Given this list of marker genes PARP1 (NCBI Gene Id 142), ATM, RUVBL1, SETMAR, TWIST1, NBN, ABL1, RADX, ACTR2, ACTL6B, DPF2 (double PHD fingers 2), RMI2, PARPBP, PML, MAD2L2, SMARCA2, KDM4D, BRD7, CYREN, RAD51AP1, PRMT1, SMARCC2, TEX15, NSD2, ZCWPW1, ARID1A, WAS, PPP4R3C (protein phosphatase 4 regulatory subunit 3C), FBH1, POLQ, PPP4R2, WDR48, UBE2N, MEAF6, RIF1, SHLD1, MGMT, SHLD2, ARID2, ATR, TP53BP1, PBRM1, SLF2, PPP4R3A, RAD50, SKP2, CREBBP, OTUB1, MORF4L1, SHLD3, SMARCD1, SETD2, MIR221, KLHL15, FOXM1, SMARCB1, SPIRE2, YEATS4, BCL7B, MRE11, UBQLN4, RTEL1, DMAP1, KMT5C, RNF169, FH, UBE2V2, CSNK2A1, HSF1, TOP2B, PELI1, OGG1, PIAS4, PPP4C, DDX11, MRGBP, FANCB, ZNF365, PHF10, PNKP, DEK, KMT5A, USP51, EPC1, FIGNL1, WRAP53, HELQ, EP400, SLF1, SPIRE1, PLK1, TFIP11, ATRIP, TERF2IP, HDGFL2, MAGEF1, ARID1B, POT1, ACTL6A, SMARCD3, HELB, KMT5B, SMARCA4, TRRAP, BCL7C (BAF chromatin remodeling complex subunit BCL7C), FMN2, KHDC3L, DPF1, SMCHD1, SPIDR, TIMELESS, BCL7A, SIRT1, RPA2, KAT5, OOEP, RNF8, PPP4R3B, SMARCC1, RAD51, BRD8, PARP3, CGAS, PRKDC, C1QBP, NUDT16L1, AGER, SMARCD2, SMARCE1, ACTB, RECQL5, FUS, DPF3, EPC2, SENP3, HMGA2, ERCC6, MBTD1, KDM1A, AUNIP, CHEK1, ING3, RUVBL2, MRNIP, VPS72, SIRT6, RNF126, MORF4L2, here is a description of the gene set: Any process that modulates the frequency, rate or extent of double-strand break repair. species: Homo sapiens Human Gene Set: GOBP_REGULATION_OF_DOUBLE_STRAND_BREAK_REPAIR